Given this list of marker genes Bax, Cd24a, Il2ra, Lmo1, Il2, here is a description of the gene set: species: Mus musculus Mouse Gene Set: GOBP_T_CELL_HOMEOSTATIC_PROLIFERATION The non-specific expansion of T cell populations within a whole or part of an organism to reach to a total number of T cells which will then remain stable over time in the absence of an external stimulus.